The following is a description of a gene set: Pili canaliculi A characteristic triangular, kidney- or heat-shaped diameter of hair shafts with typical longitudinal canalicular deformation as observable by scanning electron microscopy. studied in species Homo sapiens Human Gene Set: HP_PILI_CANALICULI, and this is the list of marker genes: PADI3, GAN, TGM3, TCHH, TP63